The following is a description of a gene set: Human Gene Set: HP_DEFORMED_TARSAL_BONES species: Homo sapiens Deformed tarsal bones, and this is the list of marker genes: COL1A2, KANSL1, TPM2, NALCN, ADAMTSL1, ATP6AP2, MET, ECEL1, GDF5, ZEB2, TNNI2, HOXD10, PHGDH, EZH2